Given this list of marker genes Scp2-ps2, Bltp1, Snx18, Adissp, Tex2, Prmt7, Gm23130, Gm15883, Pgrmc1, Wac, Runx1, Mrps5 (mitochondrial ribosomal protein S5), Stard10, Brat1, Setd1b, Ncoa1, Ilrun, Slc48a1, Rmnd1, Car3, Prdx1, Ssh1, Atp5f1b, Urb2, Pold3, 4930577N17Rik, Vtn, Ibtk (inhibitor of Bruton agammaglobulinemia tyrosine kinase), Tspan2, Actr10, Phf14, Pign, Ppara, Sik1, Wdr90, Ctnna3, Aip, E130018N17Rik, Ppp3cb (NCBI Gene Id 66215), Tle3, Cactin, Dlg5, Slc27a2, Tsga10, Cyren, Parp6, Dennd6a, Tbck, Rnf44, Agpat2, Cfap418, Sri, Rfx2, Ccdc124, Otud4 (NCBI Gene Id 73945), Dctn1, Gm29707, Yju2, Rab7, Plag1 (pleiomorphic adenoma gene 1), Ugt2b36, Psmg2, Gtf3c6, Ppp2cb, Usp32, Kcnk5, Invs, Alb, Arhgef1, Actb, Isy1, Comt, Scamp5, 4930481B07Rik, Phc2, Arf3, 1500015A07Rik, Vamp8, Arl10, 1810062O18Rik, B430119L08Rik, Gm15634, Gorasp1 (golgi reassembly stacking protein 1), G2e3, Ugp2, Aldh7a1, Prkar1b, Usp6nl, Pih1d1 (NCBI Gene Id 75728), Trps1, Srxn1, Mycbp, Stag1, Zc3h4, Bap1, Nat9, Lrr1, Mapk6, Hspa4l, Fam168b, Ccdc157, Faap20, 4930519P11Rik, Dnaaf5, Taf5l, Endod1, Med13l, Bcl2l2, Nfe2l2, Map1lc3b, Rb1, Gm5447, Lztfl1, Ssbp3, Qrich1, Nfatc3, Suds3, Pptc7, Itpa, Spcs3, Gabbr1, Smc2os, Senp2, Golga5, Stam2, Polr2e, Med4, Clk2, Tor1a, Rabl2, Gm30097, Noa1, Ing1, Ube2o, Tomm40l, Tmem30a, Tnfrsf11a, Rgl2, Mrpl11, I830134H01Rik, Nr2f6, Smc5, Asap1 (ArfGAP with SH3 domain, ankyrin repeat and PH domain1), 4930429F24Rik, Tnfaip8, Nploc4, Adipor1, Psmd12, Cadm4, Gm13830, Rbis, Erp44, Patz1, Ccdc86, Cdk12, Snord45c, Eci2, Ehd1, Mir7684, Alas1, Socs6 (NCBI Gene Id 77635), Dpcd, Pkd2, Rnf139, Ripk2, Tmem107, Sptssb, Mir210, Pgm2l1, Fbxl14, Bud31, Galnt10, 4930500F10Rik, Sik3, Rabggtb, Zfand5, Pdap1, Jun, Pacrg, Mir219c, Rbm26, Elovl2 (ELOVL fatty acid elongase 2), Ankle2, Sh3rf1, Rictor, Atosa, Ccsap, Aldh16a1, Sgpl1, Fdx1, Kdm2a, Impdh1, Magi3, Rap1b, Cib1, Tfg, Cript, Dynll1, Efcab14, Atrnl1, Nr3c1, Tmem150a, Mkks, Dennd4a, Lrrc41, Acap2 (NCBI Gene Id 78618), Dnase1l1, Rhou, Mfsd14a, Slc7a6os, Angptl4 (angiopoietin-like 4), Dnaaf9, Creld2, Snord3a, Sergef, Togaram1, Pfkfb2, Baiap2l1, Exoc2, Tafazzin, Zfp846, Lss, Dgcr8, Ackr4 (atypical chemokine receptor 4), E030042O20Rik, Slc41a3, Dop1a, Grpel2, Dzank1, Usp33, Wdr20, Prkn, Nsun2, Ints15, Mylip, Dpy19l4, Rhebl1 (Ras homolog enriched in brain like 1), Luzp1, Rragc, Dmwd, Vdac2, Alg12, Hsp90aa1, Mapk8, Arid1a, Spryd7, Elf2, Cdk5rap2, Zfp282, Mkrn1 (makorin, ring finger protein, 1), Gdpgp1, Bag6, Fbxo7, Gm10244, Ddit4, Gnl1, Ilf2, Capns1, Trf, C3, Coq8b, Rnmt, Ddx39b, R3hdm4, Papola, Sh3bp5l, Hoxa4, Ppp4r4, Pcyt1a, Rpl21, Armt1, Spink10, Nfib, Bbs5, Usp31, Nhlrc3, Clybl, Rcc1l, Phax, AI480526, Braf, Ube2r2, Alg8, Fubp1, Chchd7, Pkd1, Uqcrh, Tpgs1, Cars1, Zfp672, Ppfibp2, Mir7648, Ubxn6, Hira, Ccdc103, Lemd2, Dmrt1i, Fstl3, Pgrmc2, 1810059C17Rik, Cnot4, Fam210a, Tent4a, Ccdc30, Vamp4, Serpinc1, Serf2 (small EDRK-rich factor 2), Deaf1, Prpf39, Akap9, Cfap251, Pin4, Ring1, Heatr5a, Pip4k2b, Atp5f1e, Wdfy3, Gtf2i, Atp5mj, Kifc5b, Eftud2, Aldh2, 2810408I11Rik, Tcp11l1, Wwc1, C330013E15Rik, Eif2ak2, Ppp2r1b, Plpp5, Zfp523, Junos, Msantd2, Card10, Aimp1, Akap11, Msmo1, Mup3, Prr3, Mis18a (NCBI Gene Id 77054), Usp22, Usf2, 1700034H15Rik, Hey2, Aldob, Nktr (natural killer tumor recognition sequence), Dnttip2, Ncln, Ube2j2, Rbm14, Sh3bgrl3, Nfxl1, Smndc1, Ash2l, 2810402E24Rik, D5Ertd579e, Msh3, Lrba, Hdac1, 1700112D23Rik, D730003I15Rik, Rhobtb3, Igfbp4 (NCBI Gene Id 26902), Gorab, Them4, Nipbl, Atp6v0a1, Slc25a39, Smap1, Zfp661, Pyroxd2, Orai3, Proser1, Rab28, Sf3a1, Mrps33, Cep55, Relch, Mxd3, Txnrd2, Rpl36 (ribosomal protein L36), Srd5a1, Hpd, 2010109A12Rik, Prkcsh, Csnk1a1, Dapk3, Bcl2, Gm15579, Ccnf, Smg9, Ak6, Eif4a3, Slmap, Mmadhc, Hspa8, Gm13483, Eif5a2, Klhl28, Prkcz, Alg10b, Denr, Dut, Ccnyl1, Gm14963, Polr2b, Amd1, Odad3, Snx25, Shld2 (NCBI Gene Id 75698), Dyrk1a, Cdc42bpg, Gc, Aph1c, Ssbp2, Slx4ip, Taf9, Kmt2c, Farsb, Sp3, 1700030J22Rik, Ncapd2 (non-SMC condensin I complex, subunit D2), Cep76, Klf13, Pithd1, Alcam, Cnpy3, Phf3, Zcchc8, Ppa2, Ndufa4, Rab4b, Capn2, Smc2, Mcfd2, Slc22a15, Mrpl51, Gm22589 (predicted gene, 22589), A530072M11Rik, Exoc7, Tm7sf3, Fah, Nedd4, Mapk14, Oma1, Pigf, Dnajb4, Zfp687, Vars1, Mapkapk5 (NCBI Gene Id 17165), Poll, Supt5, 4933433G15Rik, Kiss1r, Kmt5b, Zfp346, Brwd1, Trp53bp1, Bcl9, Saa4, Ifngr2, Polr3f, Odc1, A930032L01Rik (RIKEN cDNA A930032L01 gene), Phf7, Wdr5, Acadl, Fbxo38, Ergic1, Fam76a, Napepld, Gm21992, Ttc21a, Shf (NCBI Gene Id 435684), Pi4kb, Oxr1, Zfp335os, Rnd2, Tmem134, Txndc15, Col23a1, Micos10, Nop56, Plbd2, Ufm1 (ubiquitin-fold modifier 1), Tmem104, Cecr2, Adss2, Prepl, Atl2, Zbtb7c, Pbx2, Etf1, Rps12, Scp2, Fam8a1, Tmem80, Gm10655, Rad17, Camkmt, Cdh2, here is a description of the gene set: Mouse Gene Set: NR0B2_TARGET_GENES from publication Yevshin I, Sharipov R, Kolmykov S, Kondrakhin Y, Kolpakov F (PMID 30445619) studied in species Mus musculus Genes containing one or more binding sites for (Nr0b2) in their promoter regions (TSS -1000,+100 bp) as identified by GTRD version 20.06 ChIP-seq harmonization.